Given this list of marker genes Sirt2, Cd74, Apoc2, Avp, Srebf1, Agt, Rgn, Elovl5, Slc45a3, Ptgs2, Apoc2l, Pla2g3, Mlxipl, Mid1ip1, Apoa5, Anxa1, Nr1h3, Abcd1 (ATP-binding cassette, sub-family D member 1), Abcd2, Mapk9, Nr1h2, Kat2b, Lpgat1, Apoa4, Pla2g4a, Avpr1a, Il1b, Hnf4a, here is a description of the gene set: Mouse Gene Set: GOBP_POSITIVE_REGULATION_OF_FATTY_ACID_BIOSYNTHETIC_PROCESS species: Mus musculus Any process that activates or increases the frequency, rate or extent of the chemical reactions and pathways resulting in the formation of fatty acids.